The following is a description of a gene set: Human Gene Set: GOBP_ARGININE_CATABOLIC_PROCESS studied in species Homo sapiens The chemical reactions and pathways resulting in the breakdown of arginine, 2-amino-5-(carbamimidamido)pentanoic acid., and this is the list of marker genes: MIR21, NOS2, FAH, ARG2, ATP2B4, NOS3, OAT, ARG1, DDAH1, NOS1